The following is a description of a gene set: species: Homo sapiens Human Gene Set: REACTOME_TELOMERE_MAINTENANCE Telomere Maintenance, and this is the list of marker genes: RPA2, H4C1, RFC4, PCNA, POT1, H2AX, POLA2, POLR2J, H4C9, H2BC14, CHTF8, H2BC26, TERF2, H4C2, H2AZ2, NOP10, POLR2B, H3-3A, POLD1, RTEL1, H2BC12, H2AC20, H2AB1, H4C4, GAR1, CCNA2, PIF1, H2BC5, POLR2D, H3-4, H2BC15, H2BC21, WRN, H2BC13, POLR2A (RNA polymerase II subunit A), H4C16, POLR2K, H2BC8, RUVBL1, H2BC17, TINF2, BLM, H2BC3, POLR2L, H2BC7, PPP6C, RPA3, PRIM1, RPA1, H2BC9, POLD4, H2AC4, DAXX, POLR2I, NHP2, H2BC11, RFC5, TERF2IP, H4C12, TEN1, H4C14, POLR2F, TERF1, H4C5, H2BC4, H4C6, PPP6R3, TERT (NCBI Gene Id 7015), H2AC8, H2AC6, H2BC12L, POLD3, DKC1, H2BC10, H3-3B, POLR2G, ANKRD28, H2AC19, H2AJ, H4C8, POLR2H, RUVBL2, DSCC1, H4C13, CCNA1, CHTF18, POLA1, POLD2, H2AC18, STN1, WRAP53, CTC1, RFC2, RFC3, H2AC14, RFC1, ATRX, H4C11, ACD, POLR2E, POLR2C, H2BC1, CDK2, PRIM2, H2AC7, H4C3, H4C15, SHQ1, DNA2, FEN1, LIG1, H2BC6